Given this list of marker genes Ncbp1, Nudt21, Zfp667, Tnrc6b, Arid2, Insr, Rhoq, Trir, Ccdc50, Atxn7, Gm11992, Rgs4, Lrrn1, Ube2o, Rhbdl3, Bcl3, Dcaf10, Lrp4, Dach1, Mthfr, Bmal2, Trim36, Ilrun, Kpna4, Nsd2, Srsf10, Ap1s2, Sh3rf1, Scfd2, Sptlc3, Tpcn1, Inpp4b, Nampt, Rprd1a, Prrg3, Rab11fip5, Ncor1, Syde1, Nfat5, Slc38a1, Dcdc2a, Duxbl1, Syt15, Sgcb, Cxxc4, Suco, Aacs, Cnn1, Ado, Slc2a10, Cntnap2, Nfe2l1, Rassf2, Anapc10, Mycbp, Naa15, Slc6a1, Mvb12b, Ppp6c (NCBI Gene Id 67857), Kbtbd2, Phf13, Kif21b, Rtp1, Prr16, Mars2, Atp11a, Zbed6, Shc1, Extl3, Adgrf1, Kcnd2, Ptpre, Kcnk10, Arid4a, Onecut2, here is a description of the gene set: Mouse Gene Set: MIR_764_5P Genes predicted to be targets of miRBase v22 microRNA mmu_miR_764_5p in miRDB v6.0 with MirTarget v4 prediction scores > 80 (high confidence targets). from publication Chen Y, Wang X (PMID 31504780) studied in species Mus musculus